The following is a description of a gene set: Abnormal inner ear morphology A structural anomaly of the internal part of the ear. Human Gene Set: HP_ABNORMAL_INNER_EAR_MORPHOLOGY studied in species Homo sapiens, and this is the list of marker genes: TRRAP, OTX2, RAF1, CDH23 (cadherin related 23), SIX1, SLC26A4, CHD7, MYO7A, POLR1C, POLR1B, RIT1, ORC1, COL4A6, AIFM1, FOXP2, NRAS, MT-TS2, SEMA3E, ARSG, LZTR1, RRAS (RAS related), RRAS2, KMT2D, PI4KB, POU3F4, KDM6A, FOXI1, TIMM8A, KRAS, HARS1, MAP3K7, FGFR3, SPRED2, CHN1, AHDC1, HAAO, NEUROG1, USH1G, POLR1D, PTPN11, USP48, CEP78, ANKH, SIX5 (SIX homeobox 5), THOC1, TCOF1, USH1C, FGF3, SALL4, MRAS, ESPN, GJB6, COCH, SOS1 (SOS Ras/Rac guanine nucleotide exchange factor 1), PRRX1, DDX11, SRCAP, FGFR2, GJB2, PCDH15, GREB1L, KCNJ10, TWIST1, CIB2, RASA2, CBL, SOS2, CCDC50, EBF3, ABCC1, HRAS, EYA1, CLRN1, SOX10, AKT1, NDP, ESRP1, SETBP1, MAFB, PEX6, ERF